Given this list of marker genes Pafah1b1, Cntn2, Vpreb1b, Sctr, Arhgap18, Twf2, Mtor, Rhoa, Fhod3, Cit, Mgll, Aqp1, Eps8, Clec2i, Naa80, Arhgap40, Rab5a, Tpm1, Dcx (NCBI Gene Id 13193), Mfn2, Spta1, Pex11a, Trp73, Lrrc8e, Cfl2 (NCBI Gene Id 12632), Nck2, Nckap1l, Rtn4r, Rgma, Vill, Pou4f2, Ilk, Lamtor4, Rnf6, Pten, Cyrib, Ep300, Arpc3, Bmpr2, Sh3bp1, Clns1a, Wnt7a, Arpc5, Wdtc1 (WD and tetratricopeptide repeats 1), Ret, Myadm, Dip2b, Actr3, Cdc42ep5, Akt3, Crabp2, Gla (NCBI Gene Id 11605), Mt3, E2f4, Prkg2, Borcs5, Atp2b2, Map3k13, Ulk1, Bbs4, Ccl21e, Pex11b, Neb, Epha7, Map2, Myo3a, Wnt5a, Cav3, Smurf1, Fgf13, Pak1, Draxin, Lrp1, Arhgap4, Rasa1 (RAS p21 protein activator 1), Nefl, Pik3r2, Rb1cc1, Macf1, Ntn1, Ogt, Fchsd1, Nrp1, Mapt (NCBI Gene Id 17762), Sptb, Swap70 (SWA-70 protein), Twf1, Inf2, Was, Trpv2, Specc1l, Kank3, Arhgap35, Rtn4, Ssh1, Fstl4, Rab3b, Gba2, Hsp90aa1, Zfyve27, Wnk3, Pdxp, Myo1c, Disc1, Slc6a12, Gm14137, Pls1, Map3k7, Nckap1, Nkx6-1, Ssh3, Grb2, Sin3a, Edn1, Svil, Cdc42ep3, Cfl1, Lpar3, Tnr, Prex1, Rictor, Map3k1, Capza3, Iqgap3, Capzb, Hp1bp3, Arf6, Slit1, Flii, Ngf, Carmil1, Shank3, Col6a1, Dscam, Pak3, Coro1a, Evl, Tmod1 (NCBI Gene Id 21916), Vil1, Ccl21d, Kank1, Wnt7b, Slc12a3, Cyria, Mlst8, Capza2, Lmod3, Cyfip1, Abitram, Wnt3a, Borcs6, Plekhh2, Capza1, Kel, Washc1, Cyfip2, Ssh2, Dnm1, Bin1, Fshr, Kcnma1, Capza1b, Vav2, Cdk5, Ulk2, Rptor, Als2, Ppp1r15a, Myo5b, Cdh4, Tenm1, Cdh1, Sema3f, Icam1 (NCBI Gene Id 235038), Slc12a2, Kank4, Myo3b, Slit2, Cdc42ep4, Adnp, Tsc2, Vegfa, Cracd, Chmp3, Aqp11, Esam, L1cam, Pfn5, Vav3, Sema5a, Tmsb15b2, F2rl1, Plekhg2, Hax1, Snapin, Capn1, Tmod2, P2rx7, Slc12a7, Cdc42ep1, Pex11g, Sema3g, Ttc3, Add1, Megf8, Rnd2, Pum2, Kank2, Eif2b2, Rab22a, Tsc1, Washc5, Eif4g2, Lmod2, Elavl1, Shroom2, Dmtn, Fn1, Plxna4, Adcy10, Rpl4, Rapgef3, Alox15, Fer, Gsn, Ccr5, Stk39, Il7r, Myh9, Rin3, Lima1, Mtpn, Csf3, Ccl24, Msn, Fchsd2, Ush1c, Hip1r, Barhl2, Omg, Snx9, Bdnf, Wdr1, Vasp, Gsk3b, Dbnl, Wnt3, Ifrd1, Arhgap5, Trim46, Cln3, Cln8, Sptan1, Pfn1, Golga4, Abcb8, Trpc5, Efna5, Ccl26 (C-C motif chemokine ligand 26), Slc12a8, Nefm, Wdr36, Cotl1, Slc12a6, Cxcl12, Map1b, Rufy3, Nherf1 (NHERF family PDZ scaffold protein 1), Gprc5b, Pfn3 (NCBI Gene Id 75477, profilin 3), Wnk1, Lats1, Bloc1s1, Dnm2, Nphs1, Add2, Pycard (PYD and CARD domain containing), Lrrc8a, Sct, Tmod3, Picalm, Atp13a2, Bloc1s2, Cdkl3, Sema4d, Ccl11, Npm1, Spart, Abl1, C1qtnf9, Prkd1, Oxsr1, Sema4f, Eln, Dbn1, Sptbn1, Prkcd, Tmsb4x, Bcl11a, Ntrk3, Kcnn4, Rab21, Pclo, Pik3ca, Vav1, Plxna3, Add3, Sema6d, Ucn, Cttn, Borcs7, Tlr2, Arhgap32, Clcn3, Ccl21f (C-C motif chemokine ligand 21F, NCBI Gene Id 100504346), Baiap2l1, Shtn1, Mir205, Mag, Prkce, Ptprs, Dstn, Slc12a5, Rdx, Xk (X-linked Kx blood group), Kdm6a, Atp7a, Lamtor5, D130043K22Rik, Arpc2, Ndel1, Vpreb1a, Creb1, Islr2, Slc26a5, Arpc5l, Mkks, Ptk2b, Arfgef1, Hcls1, Pecam1, Lars1, Limk1, Cdk4, Hdac6, Sema7a, Aqp4, Kxd1, Scin, Arhgap28, Aqp2, Slc12a9, Ccl21a, Capg, Fxn, Rac1, Clasp2, Hsp90ab1, Borcs8, Baiap2, Daam2, Gdi1, Akt1s1, Fmn1, Cdc42ep2, Carmil2, Ano6, Ppp1r9a, Pfn2, Slc12a4, Brk1 (BRICK1, SCAR/WAVE actin-nucleating complex subunit), Kdm1a, Slc12a1, Olfm1, Cdkl5, Deptor, Prr16 (proline rich 16), Ccl21b, Dnajc16, Ccdc51, Kirrel1, Plek, Ezr, Actn2, Cdhr5, Ist1, Lmod1, Ap2m1, Tnfrsf12a, Ahr, Apoe, Akt1, Sema6c, Bag4, Anxa7, Tmsb15l, Anapc2, Avil, Tmod4, Sema3a, Nck1, Cdhr2, Gnb3, Srf, Ryk, Dlg1 (discs large MAGUK scaffold protein 1), Ttl, Baiap2l2, here is a description of the gene set: studied in species Mus musculus A process that modulates the size of a cellular component. Mouse Gene Set: GOBP_REGULATION_OF_CELLULAR_COMPONENT_SIZE